Given this list of marker genes VAMP1, RCBTB2, SLC35C1, ARHGAP29, SLC16A5, ATP6V0A2, SIDT2, CHD7, TSPAN10, WNT1, SLC30A1, ELK1, SLC39A14, ANKRD13D, ZNRF3, GPRC5B, MLLT11, LYPD6B, SATB1, SCML4, OVGP1, THEMIS, TRAM1, SLCO3A1, TACC2, RHOT2, CTDSP2, EIF2AK3, FBXO9, CAP2, APBB3, FAM120AOS, FBLIM1, GZMH, SETD4, FADS3, SLC6A4, OSBPL9, ZHX3, EGR1 (NCBI Gene Id 1958), DMTF1, CPA4, OTUD1, KL, NXF1, UBE2D1, CYP2S1, PXK, EVI2B, AKAP6, COMMD9, TANC1, DAB2, CSRNP2, ZCCHC12, PEX12, HP1BP3, GUCD1, PKHD1L1, PIP4K2A, C1orf21 (NCBI Gene Id 81563), INPP5B (inositol polyphosphate-5-phosphatase B), EGLN2, USP12, TMEM35A, RFLNB, MTUS2, CCDC71L, TLR6, SLC35E2B, AP3D1, TMEM63A, EPCIP, PAM, ARL5B, VCAN, SIKE1, ARHGDIB (Rho GDP dissociation inhibitor beta), PIGK, ENC1, PIK3IP1, ACVRL1, SLC12A7, EEIG1, NEURL1B (neuralized E3 ubiquitin protein ligase 1B), CAPNS2, APOL2, IRGQ, NSG2, ARHGAP22, TMEM59, GPR18, CHST15, STEEP1, AP4E1, NAP1L4, PTPN6, MYLIP (NCBI Gene Id 29116), ZNF483, GRK6, ANXA6, MITF, NSF, CYP3A4, RIGI, MFSD8, NPC2, TINAGL1, RAPGEF4, SOS1, VIPR1, SLC22A12, ABTB3, CPM, KBTBD7, ELOVL7, ERICH3, PITPNC1, CST9L, TSPAN14, MFSD3, RAP2C, MINK1 (NCBI Gene Id 50488), CDYL2 (NCBI Gene Id 124359), ALDH1A1, ST8SIA1, HOXA2, GGT1, ZNF14, LPAR6, TERF1, TMEM170B, AK1, ABHD14B, RNASE6 (ribonuclease A family member 6), TTC7B, TNFRSF1A, DUSP6, PDLIM4, ADCY7, EPB41, SYN1, GPR137B, KCNMB4, TAPT1, ODAM, ARL4C, TRIM56, ANKRD11, LRRC8A, ACAP1, RREB1, BCAN, CD207, RPH3AL, SGMS1, SPTBN1, XKRX, KREMEN1, P4HA2, ADCYAP1R1, GRM7, EXPH5, METTL9, ARHGEF11, P2RX4, NRAS, CDO1, LYST, TIMP2, FAM78A, ZBTB33, IL1RL2, FRAT2, PDE3B, CNOT3, ZNF512B, SGK1, TET1 (NCBI Gene Id 80312), SEC16B, CEP97, ACP3, DYRK2, NFE2L2, CD47, SLC9A6, AAK1, KRTAP4-6, ACVR1B, EZH1, ZFP36, CYP4X1, ITGB3, QSOX1, KCNB1, PPP1R13B, CNGA1, FZD6, TDRP, SLC20A1, here is a description of the gene set: Human Gene Set: GSE7460_TCONV_VS_TREG_THYMUS_UP Genes up-regulated in comparison of TconvThy versus TregThy (see Fig. 1 in the paper for details). from publication Hill JA, Feuerer M, Tash K, Haxhinasto S, Perez J, Melamed R, Mathis D, Benoist C (PMID 18024188) The transcription factor Foxp3 is usually considered the master regulator for the CD4+CD25+ studied in species Homo sapiens